The following is a description of a gene set: Human Gene Set: GOBP_POSITIVE_REGULATION_OF_B_CELL_DIFFERENTIATION species: Homo sapiens Any process that activates or increases the frequency, rate or extent of B cell differentiation., and this is the list of marker genes: PCID2, MMP14, NCKAP1L, CD27, DDRGK1, IL10, BTK, STAT5A (NCBI Gene Id 6776), STAT5B, SYK, IL2, IL7, IL2RG, XBP1, INPP5D, BAD (BCL2 associated agonist of cell death), SPI1, PPP2R3C